Given this list of marker genes CD27, TNFRSF25, TNFRSF1B, TNFRSF9, TNFSF11, TNFRSF4, TNFRSF6B, TNFSF13, TNFSF6, EDARADD, TNFRSF8, TNFSF4, TNFSF13B, TNFRSF14, CD70, EDA2R, TNFRSF13B, TNFRSF1A, TNFSF18, TNFSF8, TNFRSF18, LTA, TNFRSF11B, EDAR, TNFSF14, TNFSF9, TNFSF15, TNFRSF17, EDA, here is a description of the gene set: Reactome Pathway: TNFs bind their physiological receptors part of: TNFR2 non-canonical NF-kB pathway Members of the tumour necrosis factor superfamily (TNFSF) and TNF receptor superfamily (TNFRSF) have crucial roles in both innate and adaptive immunity. These members are implicated in various acquired or genetic human diseases, ranging from septic shock to autoimmune disorders, allograft rejection and cancer. species: Homo sapiens